Given this list of marker genes Snrnp27, Hgs, Borcs8, C130060C02Rik, Rab43, Mrps21, Mkrn3, Rpl28, Sirpa, Ndufs1, Myo18a, Sf3a2, Thap6, Snord55, Slirp, AI429214, Gpank1, Ccnd2, Sec61a1, Mfap3, BC031181 (cDNA sequence BC031181), Eef1b2, Lin9, Sgo2a, Abhd3, Zbtb49, Sox1, Pom121, Klhdc10, Erlin1, Tgm2, Rab1a, Mtss1, Zc3h18, Cdk10, Pcyox1 (prenylcysteine oxidase 1), Bms1, Pkmyt1, Dhx8, Sptlc1, Triobp, Vapb, Trim37, Ilrun, Tm9sf2, Vars2, Aptx, Pwwp3a, Atxn7l3b, Trmt112, Lats1, Prpf38a, Ica1l, Slc24a2, Synj2, Leo1, Snap23, Rrn3, Csnk1a1, Gm15952, Nvl, Ptprj, Dctn4, Secisbp2, Ipo13, Phf5a, Trim11, Mrpl20, Eif3c, Btf3, Farsa, Vps11, Dguok, Msi2, Rnf20 (ring finger protein 20), Msh6, Fbxo45, Ddx17, Misp3, Rps7 (NCBI Gene Id 20115), Vps45, Dlgap4, Zfp420, Gtpbp6, Wdr26, Erlin2, Gm26205, Dipk2a, Copa, Kcnj4, Rab1b, Cnot10, Dnttip2, Gpr137b, Taf12, Zfp646, BC005624 (NCBI Gene Id 227707), 2810004N23Rik, Sigirr, Zbtb8os, Dnajc19, Rfxank, Rpl27, Kbtbd8os (NCBI Gene Id 72217), Gm10419, Ckap2l, Zfp622, Sh3glb1, Ints12, Zdhhc4, Slc37a3, Syvn1, Fbln7, Rars1, Sde2, 2410004B18Rik, Rbfox2, Snf8, Zfp598, Mettl21a, Gucd1, Znfx1, 2810405F17Rik, H4c3, Raf1, Slc35a3, Bcl9l, 3110040N11Rik, Glg1, Llgl2, Nktr, Tmbim4, Polr3b, Snu13, Vta1, Smu1, Vegfa, Urm1, Ccdc73 (NCBI Gene Id 99265), Trp53rkb, 1500015A07Rik, Mctp1, Znrd2 (NCBI Gene Id 66232), Psma6 (proteasome subunit alpha 6), Cwc25, Dzip3, Sgsm1, Aldh9a1, Vps9d1, Mecr, Mtfr1l, Psmg1, Kics2, Pou4f1, 1110065P20Rik, Rnaseh2b, Yme1l1, Lsm7, Scrib, Rbm15b, Zfp61, Ankrd44, Snx3, Dyrk3, Tab2 (NCBI Gene Id 68652), Pttg1ip, Bdp1, Cdkn2c, Rplp1, Knop1 (lysine rich nucleolar protein 1), Slx4, St13, Mrps16, Nme1, Mettl4 (methyltransferase 4, N6-adenosine), Dffb, Lmo4, Acad10, Arfrp1, Armc6, Ccdc25, Sugp2, Prdx5, Xrn2, Gins4, Sae1, Mier1, Asb6, Gm9694, Ccar2, Ikzf5, Gdap2, Pomgnt1, Glod4, Pigc, Dab1, 4930500F10Rik, Zfp82, Fis1, Gm25541, Gm28535, Emg1, Tmem106c, Mrps35, Scrn3, Tma16 (translation machinery associated 16), Socs3, Zfp668, Scaf11, Mvd, Fastkd3, Mus81, Ndufb10, Dcun1d1, Nuf2, P3h2, Sec13, Scarb2, Dnajc30, Rps14 (NCBI Gene Id 99773, ribosomal protein S14), Nek9, Gm15420, Cpsf1, Btbd10, Hsf4, Rab7, Immt, Zkscan1, Yipf6, Isy1, 3000002C10Rik, Upf1, Arhgdia, Bbs10, Dazap1, Ppp4r3a (protein phosphatase 4 regulatory subunit 3A), Zbtb6, Tpgs2 (NCBI Gene Id 70531), Tmem116, Celsr2, Nsun3, Mrpl48, 5430400D12Rik, Caskin1, Larp1b, Srpra, Stpg1, Etnk1, Mtrr, Rsf1os2, Med13l, a, Gpam, Nifk, Mettl14, Atg7, Ttc1, Ncbp2as2, Tufm, Atp13a3, Gpbp1, Acad9, Kpna1, Hbp1, Catsper2, Bin3, Fank1, Rps21, Nup153, Ddx19a, Myo19, Tm7sf2, Eif2s1, Wiz, Zfp11, Phb2, Dbnl, Fam76b, Riok3, Nip7, Gm25878, Ndufaf1, Uba2, Rad50 (NCBI Gene Id 19360), Mir7653, Rnf139, Stard7, Tulp4, Fbxo8, Atxn1l, Npc2, 4933431K23Rik, Gm26704 (predicted gene, 26704), D8Ertd738e, Itgb5, Bcdin3d, Mitd1, Prkrip1, Tbk1, Prpf31, Phkg2, Dus1l, Brap, Chtf8, Acot8, Gpn2, Elac2, Qtrt1, Mrm3, Cops7b, Perp, Taf1c, Slx9, Zfp60, Rtca, Thoc5, Rnf25, Ubxn2b, Utp6, Sf3b1, Rpl29 (NCBI Gene Id 19944), Txnl4a, Cog6, Zbtb41, 6330562C20Rik, Park7, Bysl, Mir1900, Rmnd5a, Pgm2l1, Ric8a, Tsc2, Id4, Esyt3, Rpl37, Lrrc47, Smad5, Pim1, Ung, Tmem184c, Nol4, Mex3b, Ssr1 (NCBI Gene Id 67100), 4930429F24Rik, Gm15564, Pfn2, Tmco3, Lrch4, Naa35, Lyrm2, Tmed2, Impa1, C530005A16Rik, Glt28d2, Ncoa6, Eif2d, Rtn3, Cib1, Atp6v1a, Aldh7a1, Ccl25, Psmd13, Zbtb14, Lyrm4, Wac, Atad2, Edc4, Msl1, Ints3, Xpo5, Rack1, Uspl1, Mettl25, Tatdn1, Gin1, Slc25a25, Mrpl1, Fam110a, Sergef, Sdhb, Yrdc, Pmpca, Spopl, Zxdc, Isl1, Stoml2, Dclre1b, Nsun5, Sdhaf2, Srsf1, Zfp408, Ccdc142os, Alyref, Tmco1 (NCBI Gene Id 98577), Cant1, Phospho1, Rbm42 (RNA binding motif protein 42), Vps52, Raly, Rtn1, Arpc5l, Unc50, Rps11, Acin1, Lypla2, Cdc27, Arih2, Gnai3, Idh3b, Gm13421, 2310068J16Rik, Map3k1, H2bc18, Ddx27, Mrpl39, Vmp1, Nsmce4a, Egr2 (early growth response 2), Engase (endo-beta-N-acetylglucosaminidase), Bud31, Wdr53 (NCBI Gene Id 68980), Ablim3, Pigm, Slf1, Tnfaip8, Dagla, 2310061I04Rik, Ykt6, Gtpbp10, Fibp, Tmem68, Rmdn1, Ccdc17, C920021L13Rik, Ppp1r11, Osbpl11, E2f2, Galk2, Nom1, Igsf11, Timmdc1, Acaa1a, Gtf2h5, Ubtf (NCBI Gene Id 78596), Hsp90ab1, Zfp213, Rif1, Tcfl5, Zfc3h1, Atp5mc2, Birc6, Sec23ip, Nrm, Cdca5, Gpr75, Zfpm1, Trmt13, Unc119b, Shb, Cog8, Zfpl1 (NCBI Gene Id 81909), Tsku, Cbfb, Tbp, Cep104, Taf7, Ppm1g, 1700028E10Rik, 1110035H17Rik, Acbd3, Gm10244 (NCBI Gene Id 638719), Wnt7b, Art5, Dcaf7, Fcho2, Eps15l1, Phf7, Ccdc103, Myd88, Brd9, Zdhhc20, Cfap57, Rhbdd1, Chmp5, Cep57, Gm20522, Srr, Rchy1, Tlnrd1, Pkd2l2, Ptpn11, Orc1, Septin7, Whrn (NCBI Gene Id 77624), Mxra7, Nop58, Rlim, 4933425M03Rik, Ube4a, H3f3b, Gm4890, 0610040B10Rik, Atp6v1d, Bloc1s6os (NCBI Gene Id 75915), Faf2, Pex3, Acbd5, Med21, Arf4os, Kif22, Letmd1, Trmt5, Palb2, 8430429K09Rik, Dele1, Ccdc14 (NCBI Gene Id 239839), Dnajc14, Gm3807, Mtif2, Psmd2, Ccnt1, Gm11936, Cad, Erlec1, Ak6 (NCBI Gene Id 102216272), Krit1, Ppig, Mapkap1, Dusp16, Exosc2, Sdcbp, Eloa (elongin A), Dda1, Pde7a, Aldh18a1, Noc2l, Zfp846, Tbx3, Edc3, Mrpl51 (mitochondrial ribosomal protein L51), Sdf4 (NCBI Gene Id 20318), Tnfsf13os, Tmx3, Rps10, Stk11ip, Luc7l, Tmed3, Ublcp1, Pofut2, Sh3bp5l, Ap3s2, Sirt3, Dvl3, Gm13033, Orc3, Srp14, Oat, Ubac2, Srsf11, Tmem120a, Mcoln1 (mucolipin 1), Capza2, Mm2pr, Pthlh, Gm12762, Synm, Cdkl3, Ssr2, Rpap1, Mast3, Uhrf2, Gm29257, Asphd2, Aco2 (aconitase 2, mitochondrial), Gm14455, Fbxl12, Cox7a2, Pop7, Cdadc1, Prdm1, Ccdc88c, Nipal3, Cnih4, Fbxl6, Nsf, Ap1b1, Duox2, Xpo7 (exportin 7), C87436, Myl4, Alg8, Prim2, Rab10os, Bag1, Rps19, B4galnt1, Uqcr11, Trpm8, Selenoo, Apbb2 (amyloid beta precursor protein binding family B member 2), Togaram1, Capns1, Twnk, Eif3h (eukaryotic translation initiation factor 3, subunit H, NCBI Gene Id 68578), Gtf2h3, Iqcg, Cnpy3, Adamts15, Myrf, Clns1a, Gm10840, Iqck (NCBI Gene Id 670145), Dnaja4, Fbh1, Dnajc9, Golga1, Rbck1, Anp32a, Zfp276, Tor1a (NCBI Gene Id 30931), Nsl1, G2e3, Synj2bp, Tmem167b, Mrpl30, Prpf18, Sf1, Tomm20, Emc3, Llgl1, Parg, Wrap73, Ap5z1, Rpl24, Ubl5, C1qbp, Yipf2, 1700042D02Rik, 5730480H06Rik, B3gat3, Tada1, Cbx5, Mapkapk2, Adsl, Rbsn, Mllt1, Tmem44, Fbxo24, Ranbp6, 2310058D17Rik, Snx18, Ftsj3, Rgs7, Cisd2, Preb, Dctn5, Cep126, Mkrn1, Gm14023, Bad, Bnip2, Fam114a2, AW554918, Ltv1, Fbxl8, Ttll5, Taco1, Sec31a, Iqank1, Mettl23, Agbl5, Pomt1, Rpl35a, Gm24016, Ankrd16, Rsl24d1, Gm26397, Ptrh2, Pdk1, Washc5, Mcm3ap, Slc25a12, 1700041I07Rik, Polh, Pou2f1, Rpl38, Elmo1, Gm20675, E2f1, Cdk13, Ankra2, A130010J15Rik, Nmrk1, Mrs2, Gm38250, Adrm1, Nup50, Pabir1, Rpl18, Cers2, Rps19bp1, Hnrnpa1, Zfas1, 4930405A21Rik (NCBI Gene Id 74846), Rbm8a, Prpf3, Saysd1, Pstk, Ttyh3, Bicdl1, Washc1, Rfx7 (NCBI Gene Id 77004), U2af2, Appl2, Ypel3, Gna13, Ercc2, Nsmce2, Mnt, Gm17435, Zfp235, Tpp2, Mir423, Zfp12, Srsf9, Cep83os, Mir6236, 1600020E01Rik, Rps26, S2bpcox16, Fyco1, Nup214, Gm13377, Brk1, Eif4g2, Brat1, Fbxw8, Acvr2a, Mtmr14 (myotubularin related protein 14), Zc3h10, Klf15, Psmd11, Bzw2, Rpl34, Wdr4, Tatdn3, Uba52, Ubxn6, Snora73a, Slc66a3, Dcp1a, Ttc9, Med6, Fads1, Pdia3, Fhod3, Sec61b, Gm15938, Mrpl27, Nrp2, Ubp1, Zw10, Fbxw2, Tssk6, Gm9955, Tfb1m, Nmnat1, Akap13 (NCBI Gene Id 76109), Trip13, Fastkd5, Prelid1, Psmc4, Pgs1, Prkab1, Sf3b6, Nfx1, Slc5a6, Taf11, Aasdh, Polr2m, Trmt1l, Gm20605, Hipk3, Tmem106b, Pigt, Pithd1, Smap1, Usp7, Taf1a, Ttc14, Daxx, Grk4, Asic1, Sap18, Eif3i, Lrrc8b, Bnip3l, Pnn, Smad2, Ebna1bp2, Arv1, Ctif, Cdc34 (NCBI Gene Id 216150), Etohd2, Rpsa, Triap1, Ubr4, Arl16, Frs3, 1810019D21Rik, Norad, Serac1, Cbx3, Phlda3, Klhl36, Mettl6, Pigp, Amph, Rad23a, Rcc1, Ubxn7, Pced1b, Tgds, Ranbp3, Tfpt (TCF3 (E2A) fusion partner), Coa5, 4933417C20Rik, Ank2, Dph3, Zfp865, Srcin1, Nt5c2, Acsl4, Eaf1, Ecd, Opa1, Klhdc2, Zfp558, Prpf8, Yeats4, Atp2c1, Hdgfl3, Fars2, Stx16, Kbtbd8, Rab4a, Phf12, Brsk2, Utp11, Gm40332, 1110006O24Rik, Mir7075, Zng1, Slc9a8, D17H6S53E, Psmc5, Timm10, Akap8l, Acacb, Chaserr, Egr1, Haus5 (HAUS augmin-like complex, subunit 5), Tysnd1, Myl12a, Hmgxb4, Zfp703, 5430405H02Rik, Gm13283, Tfdp2, Tradd, Slc39a13, Ggct, Aimp1, Senp1, Dock3, Cope, Morn2, Smarcc2, Rnf149, Fam98a, Rhpn1, Clpp, Tle2, Tmem147, Max, Mcrs1, Rapgef1, Elmod2, Zfp638, C330018D20Rik, Ankle2, Kdm5b, Imp4, Pak1ip1, Gm10941, Noc3l, Caap1, Anapc11, Tpk1, Cog7, Nsmce1, Usp21, Atp6v0e, Lrwd1, Tax1bp1, Gsk3b, 5330439K02Rik, Dcdc5, Hnrnpu, Cic, Actn1, Sap30, Sys1, Rgl2, Atg2b, B3galt6, Shld1 (NCBI Gene Id 73747), Tmed5, Dnajc3, Cops3, Rab6a, Ttc3, Gabarapl2, Ociad1, Gm13610, B230219D22Rik, Ube2j2, Tmem203, Clybl, Polr1h, Entrep2, Hmgb1, Mbd2, Poldip2, Zfp316, Hinfp, Ebf3, Grk6, Marchf6, 1810044D09Rik, Mtpn, Gabarap, 5530601H04Rik, Gnb1, Utp15, Mrpl28, Hspa9, Acp1, 9530059O14Rik, Pcdh8, Rps20, Agk, Mir8109 (microRNA 8109), Banf1, Capn7, Eya1, Polr3gl (NCBI Gene Id 99549), R3hdm4, Ccdc85c, Hif1a, Mrnip, Pigf, Pin1, Dennd2c, Cct4, Prkag1, Arrb2, Zgpat, Taf10, Klhdc4, E2f4, 6820431F20Rik, Stx12, Eif6, Ddx49, Hmgn1, Ehmt1, Nedd4, Pnkp, Srsf4, Mrps28, Snrpe, Fbxo10, Pawr, Mettl2, Men1, Ddx47, Ubxn8, Rhbdf2, Arhgef26, Ppan, Sppl2b, Ankmy2, Tcf25, Gfod1, Nme6, Ndc80, Zbtb17, Brca1, Gm5129, Gpr19, Eftud2, Clspn, Boll, Lsm14a, Zdhhc17, Wwox, Wnt9a, Cops8, Mob3c, Gm10555, Mrpl45, Cyld, Ncln, Fbxo46, Mink1, Zpr1, Ccar1, Mknk2, Zbtb11, Zfat, Slc6a6, Tbrg1, Tbck, Dclre1a, Aggf1, Slc52a2, Hjurp, Safb, Uqcc4, Clip2, Med17, Glis3, 1700001G17Rik, Kti12 (KTI12 homolog, chromatin associated), Slc38a6, Wdr3, 2210408I21Rik, Mtcl2, Dynlt1b, Gid8, Gm16853, Usp13 (NCBI Gene Id 99731), Tefm, Rbmx2, Ttc33, Snhg3, Bmal1, Rassf1, Epn1 (NCBI Gene Id 13854), Jmjd6, Mtg2, Top3b, Rps18, Shq1, Magi1, Gm12743, Wnt2b, Zfp740, Trap1, Tbc1d7, Mtx1, Exoc8, Homer1, Cmtr2, Dynll2, 1810037I17Rik (RIKEN cDNA 1810037I17 gene), Dph1, Emc7, Ufsp1, Usp4, Srrm1, Med15, Meis1, G3bp2, Ift20 (intraflagellar transport 20), Kars1, Cog2, Ssbp1, Dnaja1, Klhdc8b, Ndufa12, Rab5if, Slc35e1, Zfp553, Tex2, Plxna4, Aktip (AKT interacting protein), Pdia5, Nol6, Nudt6, Smim8, Ski, Rora, Foxj2, Gbe1, Drg2, Psd3, Gm10649, Med18, Fam8a1, Eif2b5, Antkmt, Sass6 (NCBI Gene Id 72776), Nol12, A330035P11Rik, Chsy1, Tmed4, Mrpl44, Nup107, Syngr1, 0610010K14Rik, Tmem199, Fam171a1, Rpl35, Cir1, Herc4, Mtx2, Cox5b, Ncoa2, Tiprl, Ddx1, Gm15579, Grin2a, Eif4a3, Wdr73, Nthl1, Gnl2, Hp1bp3, Cep44 (NCBI Gene Id 71256), Synj1, Eif1ad, Rnf130, Pola2, Nelfe, Tfg, Kif16b, Ccdc186, Dock4, Snrpd2, Trmo, Mrpl32, Brca2, Ap1ar, Pcbp1, Satb1, Pcnp, Amdhd2, Amigo2, Tbc1d1, Notch2, Mrpl3, Agtpbp1, Xpnpep3, Glra1, Exoc3, Hsdl2, Tmem39a, Gnaq, Adgrb1, Zfp523, Pop4, Gm15535, Sec24a, Wnt9b, Spata7, Obsl1, Poc1b (POC1 centriolar protein B), Drg1, Morn1, Tbc1d22a, Eif4e2, Ssna1, Ndufb9, Gtpbp4, Skic2, Map3k10, Wdr45b, Nudt3, Rad17, Runx1, mt-Tv, Pus7, Mrm1, Manbal, Itgb4, Twf2, Ddx42, Ppp2ca, Mir2861, Uqcrfs1, Sar1a, Gna11, Zfp866, Lrrc40, Gps1, Atp6v1g2, 1700086O06Rik, Trmt61b, Kctd5, Eif2s2, Rnf185, Fgfr1 (NCBI Gene Id 14182), Scn5a, Dpy19l4, Zfp672, mt-Rnr2 (NCBI Gene Id 17725), Dpcd, Vps25, Ank1, Gm15327, Enho, Wdr36, Crebrf, Sptlc2, C030037D09Rik, Smg6, Hnrnpa2b1, Fdx2, Abhd17a, 3110070M22Rik, Cript, Castor1, Ess2, Afg2a, Eif2b1 (eukaryotic translation initiation factor 2B, subunit alpha), Eps15, Cep15, Ddx56, Dcaf12l1, Dhx32, Rae1, Atp13a1, Csnk2a2, Erp29, Srbd1, Nup54, Prpf4b, Gstcd, Cpe, Magohb, Pomp, Eif3m, Lysmd2, Qpctl, Kdm2a, Trmt10c, Lyar, Slc25a19, Sugt1, Arf1, Gle1, Bap1, Mdn1, Tgs1, Bet1l, Agpat3, Ralgds, Ccdc97, Ankib1, Csnk2b, Erg28, Ncaph2, 9330151L19Rik, Cacna1h, Exosc4, Arc, Bud23, Ncapd2, Med23, Cd2bp2, Capn15, Pex6, Exosc3, Fbxl12os, Zdhhc18, Gm10222, Alkbh5, Creg1, BC051226, Ppih, Ppm1l, Phyh, Taf9, Eme1, Ift56, Gatc, Rab15, Polr1f, Ift88, Jmjd1c, Ahdc1, Tomm6, Asb1, Mterf4, Alas1, Bphl, Rtf2, Lrrc41, Cttnbp2, Mastl, Zfp277, Cops7a, Mtor, Uqcc1, Entr1 (NCBI Gene Id 78707), Crtc1, Ube2g2, Stau1, Rfng (NCBI Gene Id 19719), Tmem42, Ipo8, Fam149b, Rnf14, Ipo7, Klhl20, Mir3091, Spata13, Lrrc61, Limd2, Grpel2, Thap2 (THAP domain containing, apoptosis associated protein 2), Gatb, Srsf5, Senp3, Usp30, E2f7, Arhgef5, Rabgap1l, Cep78, Rnaseh1, Mmaa, Ost4, Arfip1, Alkbh1, Prss48, Rrp15, Acbd4, Rfc4, Fzd6, Ncstn, Cul4a, Atp5if1, Ddah1, Cox7c, Cacybp, Rps6kc1, 2610020C07Rik, Slc39a3, Scube1, Rnf111, Isca2, Ccser2, 4930558K02Rik (RIKEN cDNA 4930558K02 gene), 1810024B03Rik, Gm6345, Kalrn (kalirin, RhoGEF kinase), Acadl, Sdk2, Gspt2, Mir3077, Emc4, Anapc2, Tor1b, Rreb1, Abcf1, Fam120b, Natd1, Alkbh4, Tmem62, Gm43403, Sertad2, Gm12758, Rsl1d1, 2700099C18Rik (NCBI Gene Id 77326), Gm9967, Sav1 (salvador family WW domain containing 1), Ccdc47, 4930532G15Rik, Alg2, Mthfsd, Flvcr2, Morf4l1, Kcnh3, Ube2v1, Ssu72, Rab35, Rpl37a, Adcy9, Mettl17, Ubr7, Cc2d1b, Ldlrad3, Coq2, Slc39a6, Gar1, Gdpgp1, Xpot, Vdac3, Map1s, Ccdc126, mt-Rnr1, Gdpd5, Tomm5, Pcyt1a, Rlf, Trmt6, Sowahc, Nr4a1, Mmgt1, Dmac1, Gys1, Lig4, Pnisr, Prelid3a (NCBI Gene Id 319858), Tmem9b, Sox7, Zbtb7b, Nub1, Dlst, A830082K12Rik, Vstm2a, Fhdc1, Id2, Rerg, Usp20, Atp5f1a, Ammecr1l, Hnrnpa0, mt-Nd1, Cops2, Prpsap2, Arf4 (ADP-ribosylation factor 4), Sec16a, Ndor1, Gnpat, Lingo1 (NCBI Gene Id 235402), Pola1, Ppp1r12c, Eif3a, Pcmtd2, Zfp62, Paip1, Acot7, Usp2, Rtel1 (NCBI Gene Id 99386), Rer1, Zfp94 (NCBI Gene Id 22756), Ube2z, Jph1, Wdr70, Cep83 (NCBI Gene Id 77048), Hdhd2, Tmem234, Ahcyl1 (S-adenosylhomocysteine hydrolase-like 1), Timm23, Galnt1, Tmem267, Commd5, Dync2i2, Utp23, Terf2, Mrpl12, Pdcd6ip, Septin10, Cacnb3, Cnnm4, Aff1, 4833420G17Rik, Rab26, Sfswap, Clptm1l, Purb, Tra2a, Nsa2, Ccdc115, Nudc, Cisd1 (CDGSH iron sulfur domain 1), Ap2b1, Gpr137, 2500002B13Rik, Tmem101, Tnfaip1, Fgf9, 1700022N22Rik, Nme7, 6530401F13Rik, Cdc42bpa, Mesd, Zbtb38, Psmc3ip, Ccdc77, Ciao3, Tubb5, Rpl10a, Rspo1, Ndufs7, Pnpla8, Gm20517, Fam167a, Nop14, Spg11, Wapl, Atraid, Pdcd7, Snrpb, Csnk2a1, Mfap1b, Asb3, Polr1has, Ctr9, Vpreb1a, Ankrd52, Ccdc57, Cggbp1 (NCBI Gene Id 224295), Slc25a46, Mul1, Aff3, Ebf2, Upp1, Poll, Mycbp, Snrpd3, Ddx52, Sdha, Lactb2, Wdr24, Trim24, Zfp384, Naa50, Pcid2, Dicer1, Mrps18a, Eid2, Nop2, Setd4, Blzf1, Bpnt1, Snrpc (NCBI Gene Id 20630), Sdhaf3, Dnase2a, Utp4, Vps8, Fam91a1, Gm29642, mt-Tl1, Bloc1s6, Chuk, Gm25296, 4930509E16Rik, Yipf4, Rrp1b, Gli2, Strbp, Tnpo3, Duoxa2, Usp12, Eral1, Ddost, 4933405D12Rik, Gga1, Pianp, Zmat2, Hnrnph1, Uqcrh, Dnajb6, Pcdh19, Slbp, Plekhj1, Paqr5, Slc25a36, Swt1 (SWT1 RNA endoribonuclease homolog (S. cerevisiae)), Tbc1d8, Atp6v0d1, Adprs, Gm15247, Nup155, Dusp7, A430105J06Rik, Gpd2, Uggt1, Eprs1, Tlcd1, Ppm1e, Mir7648, Tmem30a, Arhgap1, Rimkla, Hif1an, 2610005L07Rik, Cadm1, Atmin, Klhl28 (NCBI Gene Id 76837), Serbp1, Eif2ak1, Cdk9, Wdr18, Fancd2, Ark2n, Terf2ip, Ptpra, Tnk2, Mtus2, Frmpd1, Slc15a4, Macir, Pomgnt2, Ing4, Tm7sf3, Fnbp4, Bltp2 (bridge-like lipid transfer protein family member 2), Cip2a, Ncbp2, Zmym5, H4c16, Nbr1, Cchcr1, Alg10b, Prpf39, Mccc2, Dnajc24, Med20, 1810041H14Rik, Hilpda, Rps6kb1, Dapk3, Camkk2, A930012O16Rik, 6330549D23Rik, Ccdc18, Prpf6, Twsg1, Zc3h13 (zinc finger CCCH type containing 13), Arpc3, Actr1b, Ppil1, Eif2s3x, Spint1, Esrp2, Mettl3 (methyltransferase 3, N6-adenosine-methyltransferase complex catalytic subunit), Fam219a, BC025920, 4930404I05Rik, Gtf2a1, Atp11c, Txn2, Timm29, Kif26b, Mtmr9, Amfr, Rab24, Trappc10 (trafficking protein particle complex 10), Wdfy1, Sec24c, Pex12, Ogg1, Gm34106, Vav3, Bach2, Abhd18, Mei4, Gfm2, Stk36, H2az1, Mdm4, Mrps23, Ccdc124, Anapc15, Casp7, Ap4b1, Atn1, Srp19, Psmd7, Dcakd, Ccdc9 (coiled-coil domain containing 9), Nadk, Sphk2, Msl2, Cwc22, Nsrp1, Ccdc71, Snapc5, Akirin1, Dnai1, Rac1 (Rac family small GTPase 1), Nrxn2 (neurexin II), Eya3, Ccz1, Snrnp40, Ccdc59, Nmbr, Cabin1, Atp6v1e1, 3110082I17Rik, Elof1, Tmem147os, Dync1li1, Mcm8, Fndc3b, Egfem1, Rpf1, Cars1, Tsg101, Pbld2, Fam98c, Atxn2l, Glrx2 (NCBI Gene Id 98410), Mis18a, Ttc13, Mrps22, Prelid3b, Adat1, Rala, Foxred1, 1300002E11Rik, Arhgef7, Stpg2, Nol10, Map3k7 (mitogen-activated protein kinase kinase kinase 7), Slc23a2, Lamtor3, Dnpep, Psmd3, Chordc1, Gm9828, Wdtc1, Snx33, Snrnp200, Tmem128, Tmem222, Mcrip1, Mmut, Gcn1, Cables2, Mrpl53, 9130604C24Rik, Gart, Rbbp4, Rad54l, Mir207, Safb2, Atp5po, Gon7, Aaas, Vti1b, Tox2, Ltn1, Lzic, Ciz1, Atp8b2, Zswim3, 9930014A18Rik, Ube2d-ps, C1d, Ror1, Tut7, Stk19, Sgta, D930007P13Rik, Ddx55, Dxo, Tcf19, Mob2, Med27, App, Tead1, Piga, Gm26330, Ssh1, Naa12, Tyw1, Taok3, Sprtn, Tox3, Krr1, Znhit2, Gskip, Gm27042, Thop1, Gm10766, 2810013P06Rik, Litaf, Pdap1, Srebf1, Ccdc127, Rmdn3, Malsu1, Lmf2, Aldh2, Anks1, Cap1, Ranbp2, Qdpr, Fam83h, Ostf1, Gins3, Mettl4-ps1 (methyltransferase 4, pseudogene 1), Dmap1, Tubd1, Pafah1b2, Tedc2, Exoc1, Thumpd3, Pinx1, Ranbp9, Mrpl43, Rars2 (arginyl-tRNA synthetase 2, mitochondrial), Ubox5, Ppid, Rpl6, Usp8, 0610009E02Rik, Ttc17, Crtc2, 4933424G06Rik, Jpt1, Sh3yl1, Acadsb, Rps8, Cyth1, Ablim2, Elp2, Asb8, Rdh10, Son (Son DNA binding protein), Cep350, Dgat1, Dido1, Ppp3r1, Tbl3, Xkr6, Psma2, Cox5a, Oxnad1, Rfc3, 4930563E18Rik, BC030343, Ezh1, here is a description of the gene set: studied in species Mus musculus from publication Yevshin I, Sharipov R, Kolmykov S, Kondrakhin Y, Kolpakov F (PMID 30445619) Mouse Gene Set: LRRFIP1_TARGET_GENES Genes containing one or more binding sites for (Lrrfip1) in their promoter regions (TSS -1000,+100 bp) as identified by GTRD version 20.06 ChIP-seq harmonization.